The following is a description of a gene set: Subacute progressive viral hepatitis studied in species Homo sapiens Human Gene Set: HP_SUBACUTE_PROGRESSIVE_VIRAL_HEPATITIS, and this is the list of marker genes: IGF2R, CASP8, PDGFRL, TP53, AXIN1, MET, PIK3CA, CTNNB1, APC